Given this list of marker genes Cacna1c, Kcnma1, Scn11a, Chrnb2, Psap, Trpv1, Tacr1, Chrna3, Chrnb4, Umod, Ptger3, here is a description of the gene set: The regulation of body fluids process in which parasympathetic nerves stimulate the bladder wall muscle to contract and expel urine from the body. Mouse Gene Set: GOBP_MICTURITION studied in species Mus musculus